The following is a description of a gene set: studied in species Homo sapiens Any dynein complex with a homodimeric dynein heavy chain core that catalyzes movement along a microtubule. Cytoplasmic dynein complexes participate in many cytoplasmic transport activities in eukaryotes, such as mRNA localization, intermediate filament transport, nuclear envelope breakdown, apoptosis, transport of centrosomal proteins, mitotic spindle assembly, virus transport, kinetochore functions, and movement of signaling and spindle checkpoint proteins. Some complexes participate in intraflagellar transport. Subunits associated with the dynein heavy chain mediate association between dynein heavy chain and cargoes, and may include light chains and light intermediate chains. Human Gene Set: GOCC_CYTOPLASMIC_DYNEIN_COMPLEX, and this is the list of marker genes: DYNC2I2, DYNLL1, DYNLT2, DYNC1I1, DYNLT5, DYNLT4, DYNLT2B, DCTN4, DYNC1H1, DYNLRB2 (NCBI Gene Id 83657), DYNC2H1, DYNLT1, DYNC1I2, DYNC1LI2, DYNC2LI1, NUDCD3, DYNC2I1, DYNLRB1, DYNLL2, DYNLT3, SNX4, DYNC1LI1, TPR